Given this list of marker genes Rhob, Rhoc, Rock2, Rock1, Rhoa, here is a description of the gene set: Mouse Gene Set: REACTOME_RHO_GTPASES_ACTIVATE_ROCKS RHO GTPases Activate ROCKs species: Mus musculus